Given this list of marker genes Ftl1, Hspa9, Adprh, Sdc4, Ms4a6d, Jpt1 (NCBI Gene Id 15374, Jupiter microtubule associated homolog 1), Bzw1, Mrps15, Mdh2, Gapdh, Chil3, Qpct, Cox8a, Eef1g, Cish, Nop16 (NOP16 nucleolar protein), Spint1, Srm, Fabp5, Rbm3, Calr, Txn1, Hspe1, Coro2a, Ppp4r2, Rab44, Psmb3, Eif4a1, Srp9, Clec4n, Cfp (NCBI Gene Id 18636), Ostc, Ran, Reep3, Eps8, Hsd17b12, Dab2, H2-DMa, Anp32b, Srgn, Ranbp1, Cd164, Ccl24, Krtcap2, Atp5f1b, Pdia6, Capg, Ybx3, Nme1, Set, Atp5f1a, Ppp1r14b, F10, Lilrb4b, Ybx1, Tmed2, Snx3, Bhlhe40, S100a10, Ppia, Eif3a, Prkcd (protein kinase C, delta), Pebp1, Ebna1bp2, Ncl, Bcl2a1b, Tfec, Naaa, Anxa2, Dmkn, Pkm, Cfl1, Bcl2a1a, Tagln2 (transgelin 2), Ppie, Cndp2, Ffar2, Nsun2, Arpc1b, Sh3bgrl, Rexo2 (RNA exonuclease 2), Tomm22, Cstb, Gas7, Snrpf, Itgam, Bcl2a1d, Snx2, Dok2 (docking protein 2), Rpn1, Hnrnpa3, Eif5a, Vcan, Vim, Cd300lf, S100a4, Batf3, Pfn1, Pa2g4, Sidt2, Ciita, Llph, Fcgr2b, S100a6, Ppa1, Runx1, Fam162a, Myl12a, Pycard (PYD and CARD domain containing), Ctsz, Ost4, Lgals1, Pilra, Fkbp1a, Vasp, Glrx5, Klrb1f, Fbl, P4hb, Cmklr1, Irf2bp2, Msr1, Mydgf, Atp5mc1, here is a description of the gene set: from publication Cui A, Huang T, Li S, Ma A, Pérez JL, Sander C, Keskin DB, Wu CJ, Fraenkel E, Hacohen N (PMID 38057668) Cytokines mediate cell-cell communication in the immune system and represent important therapeutic targets. A myriad of studies have highlighted their central role in immune function, yet we lack a global view of the cellular responses of each immune cell type to each cytokine. To address this gap, the authors created the Immune Dictionary, a compendium of single-cell transcriptomic profiles of more than 17 immune cell types in response to each of 86 cytokines (>1,400 cytokine-cell type combinations) in mouse lymph nodes in vivo. A cytokine-centric view of the dictionary revealed that most cytokines induce highly cell-type-specific responses. For example, the inflammatory cytokine interleukin-1β induces distinct gene programmes in almost every cell type. A cell-type-centric view of the dictionary identified more than 66 cytokine-driven cellular polarization states across immune cell types, including previously uncharacterized states such as an interleukin-18-induced polyfunctional natural killer cell state. Genes positively differentially expressed in cell type: Monocyte upon treatment with cytokine: IL-3 in mouse lymph nodes in vivo. species: Mus musculus Mouse Gene Set: CUI_MONOCYTE_IL3_RESPONSE_UP